Given this list of marker genes COL2A1, BCOR, HNRNPU, H4C5, MAFB, SIX1, ARID1B, EDNRA, EDN1, WLS (Wnt ligand secretion mediator), ZFX, KIF7, WASHC5, FGD1, LRP5, DPYSL5, POLR1B, BRF1, GLI2, SEMA5A, PIGS, VPS35L, IRX5 (iroquois homeobox 5), GNAI3, VPS13B, NAA10, CCDC22, UBE3B, NSD2, LETM1, SLC4A10, WBP11 (NCBI Gene Id 51729), SMARCA2, SF3B4 (splicing factor 3b subunit 4), TASP1, SNRPN, KRAS, MSL3, CHN1, SALL4, MED13L, DACT1, KMT2D, CHD7, ALX3, CTBP1, SIX5, H4C9, POLR1D, FN1, STAG2, EFTUD2, PRMT7, SALL1, ANKRD11, CTNND2, FGFR1, TXNL4A, GPC4, CPLX1, FLNB, TMEM260, KDM6A, EXT2, B3GLCT, EYA1, SEMA3E, TCOF1, H4C3, ALX1, SVBP, FGFRL1, GPC3, SF3B2, PLCB4, ODC1, RAP1B, POLR1C, ZNF668, here is a description of the gene set: studied in species Homo sapiens Preauricular skin tag A rudimentary tag of skin often containing ear tissue including a core of cartilage and located just anterior to the auricle (outer part of the ear). Human Gene Set: HP_PREAURICULAR_SKIN_TAG